The following is a description of a gene set: Neighborhood of SUPT4H1 suppressor of Ty 4 homolog 1 (S. cerevisiae) in the GCM expression compendium Human Gene Set: GCM_SUPT4H1 Neighborhood of SUPT4H1 species: Homo sapiens, and this is the list of marker genes: NRF1, AVPR1B, TMEM106A, ZNF8, SMARCD1, CENPI, RABGGTA, KRT35, GH2, DRG2, TLK2, VPS72 (vacuolar protein sorting 72 homolog), HMGA2, MAPK3, DGCR6, RFX5, CHIC1, DDX18, ADCYAP1, DPF2, PTPRU, FCGR2A, MVK, FCGR2B, FEV, MPP2, LYST, CSTF3, SUPT4H1, BCAT2, AANAT, RING1, SLC16A1, SLC2A4, CCR9, ODF1, TRIP13, TAF1, BNIP1, FANCC, NCAPD3, TIMM17A, GRM4, CDH5, NDUFA1, MADD, APOC3, SDHC, PDE6B, COL14A1, SP2, SLC30A3, FUT2, VAV1, AAMP, MICB, NGFR, POLR1HASP